The following is a description of a gene set: studied in species Homo sapiens Neighborhood of HAT1 Human Gene Set: MORF_HAT1 Neighborhood of HAT1 histone acetyltransferase 1 in the MORF expression compendium, and this is the list of marker genes: BANF1, NDUFV1, RAD23B, HSPA9, HNRNPM, AHSA1, CCT2, PTGES3, SRSF1, CDC23, HCCS, NSDHL, POLE3, HNRNPR, HNRNPA3P1, TUFM, ESPL1, PRMT1, UBAP2L, HAT1, SOD1, EIF1AX, PCNA, CSNK2B, C1QBP, HDDC2, CEBPZ, GPN1, PMEL, PRDX3, CCNB1, UBE2N, TOMM70, SYPL1, USP1, MRPS18B, MAML1, BUB1, BAZ1B, SRP9, HNRNPU, EIF4H, VPS26A, GSPT1, PCLAF, F8A1, MTHFD1, AFG3L2, ZWINT, C6orf62, ZZZ3, ATP5PO, HNRNPAB, ICE1, LYPLA1, SUMO1, DNAJC9, COPS5, SNRNP200, EI24, UNG, PRPF31, XPO1, SNRPA, EIF4EBP2, COX7B, DGUOK, PARK7, MRPL9, MFAP1, EIF4G1, SMC1A, SNRPA1, KIF2A, RPA1, IFRD1, ALG8, NDUFS3, CAPZA1, HNRNPD, MAGOH, POLR2I, MSH2, PDHB, SMG7, RTN4, PRRC2C, ATP5PF, FAM120A, IMMT, AIMP2, RFC4, BZW1, PRPS2, MTDH, LSM2, AP3S1, NDUFC1, SRSF9, MRPL3, GNG5, STARD7, KARS1, DDX1, G3BP2, SDHB, RRM1, DLD, HNRNPA2B1, TAF11, TFDP1, H2AZ1, NUDC, KXD1, ATP5MC3, VBP1, BUB3, CDC123, FEN1, VDAC2, CHERP, CCT5, CNBP, MDH1 (NCBI Gene Id 4190), SMC3, U2AF1, SEM1, NONO, LSM3, PSMB2, TARS1, PTPN11, MRPL19, ACLY (NCBI Gene Id 47), AKR7A2, CLTC, SART3 (NCBI Gene Id 9733), VDAC1, PPM1G, DOCK3, KPNA2, NDUFB3, HSPE1, DEK, PSMB7, METAP1, FUS, AP2S1 (NCBI Gene Id 9161), UBE2E1, NDUFV2, SNRPE, SSBP1, HDAC2, HSPA4, KHDRBS1 (KH RNA binding domain containing, signal transduction associated 1), DARS1, TRAPPC3, RAD21, UBE2L3, ILF3 (NCBI Gene Id 54783), RBMX, SET, R3HDM1, NDUFS1, POM121, TRIM28, XPO7, G3BP1, TARDBP, SLBP, SKP1, RNF126, CYCS, COX5A, RAD23A